Given this list of marker genes COL5A1, COL27A1, GATA4, COL1A2, SHH (sonic hedgehog signaling molecule), PRSS1, LAMA5, COL11A2, ONECUT1, SLC4A4, NKX6-1, REG1A, COL5A3, RNASE1, LAMA4, COL1A1, CA2, LAMB3, CER1, COL2A1, HNF1B, CTRL, AQP1, AMY2A, LAMA1, KRT19, SOX17, FGF2, GATA6, LAMA3, GP2, CELA3B, PNLIPRP2, CPB1, ERICH5 (glutamate rich 5), CD74, CFTR, KRT17, CLDN10, CEL, COL5A2, CPA1, PDX1, ANXA2, CXCR4, FGF10, EGF, PLA2G1B, LAMC3, PTF1A, SERPINA4, FGF7, ANXA3, CPA2, CELA2A, LAMA2, BHLHA15, SOX9, ANXA1, PDIA2, LAMB2, VTN, FN1, AQP8, HHEX, SYCN, KRT23, SPINK1, PNLIP, YAP1, GNMT, COL3A1, LAMC1, KLK1, COL11A1, FGF4, PROM1, COL24A1, TFPI2, CTRC, LAMC2, LAMB1, KRT7, FOXA2, here is a description of the gene set: Developmental Cell Lineages of the Exocrine Pancreas studied in species Homo sapiens Human Gene Set: REACTOME_DEVELOPMENTAL_CELL_LINEAGES_OF_THE_EXOCRINE_PANCREAS